The following is a description of a gene set: A protein complex that can methylate lysine-4 of histone H3, and which contains either of the protein subunits MLL1 or MLL2 in human, or equivalent in other species. species: Mus musculus Mouse Gene Set: GOCC_MLL1_2_COMPLEX, and this is the list of marker genes: Ash2l, Pelp1, Mga, Kat8, Tex10, Kmt2b, Hcfc1, Rnf2 (ring finger protein 2), Phf20, Mcrs1, 0610010K14Rik, Taf9, Wdr5 (NCBI Gene Id 98832), Men1, Max, Taf4, Hcfc2, Dpy30, Taf1, Rbbp5, Taf6, Taf7, Prpf31, Ruvbl2, Ino80c, Kansl1, Kmt2a, Senp3, Las1l, Chd8, Ruvbl1, E2f6